Given this list of marker genes Malt1, Nlrp2, Apc, Casp12, Furin, Fap, Riok3, Serpinb9e, Serpina1c, Ryr1, Magea8, Plg, Bcl2l10, Serpina1d, Selenos, Pzp, Psap, Ins2, Casp8ap2, Timp1, Vwf, Bdkrb2, Bcl10, Mif, Ripk2, Serpinb6c, Rnf139, Stfa3, Serpinb6b, Atp9a, F2rl1, Fn1, F3, Tnfrsf1a, Csta1 (cystatin A1), Atp5f1a, Serpinf2 (NCBI Gene Id 18816), Adamts4, Fadd, Nherf4, Serpina1a, Svs3b, Serpinb6d, Brca2, Ddt, Cstb, Dvl3, Cstdc6, Adamtsl4, Serpinb9h, Tnfrsf10b, Trp53, Itgav, Ttn, Cstdc3, Serpinb3c, Pink1, Bank1, Serpinb9f, Serpine1, A2m, Itgb3, Cst3, Vcp, Mbp, Lonp2, Serpina1b, Csta2, Alppl2, Marchf6, Bfar (bifunctional apoptosis regulator), Thbs1, Anxa2 (annexin A2), Rffl, Alpi, Prnp, Fcer2a, Mug2, Cltc, Xiap, Prkn, Bag6, Hspa1a, Serpinb6e, Col1a2, Tysnd1, Fas, Insl3, Serpina5, Lcor, Aldoa, Polg, Sri (sorcin), Col1a1, Stfa1, Mbl2, Rock2, Magea3, Bin1, Il1r1, Derl1, Sart3, Lcn2, Serpinb3a, Col3a1, Adrm1, Spata2, Kit, Panx1, Elane, Sh3pxd2a, Ldlr, Mbl1, Serpinb13, Ntrk2, Chl1, Cflar, Sumo1, Park7, Stfa2, Serpinb9d, Ccbe1, Svs3a, Cstdc4, Amfr, Ecm1, Tnf, Cd177, Akp3, Serpinb3d, Nlrc4, Ctsg, Syvn1, Pten, Ins1, Magea9, Nos1ap, Serpinb9c, Serpinb6a, Serpinc1, Twnk, Serpinb9b, Hspg2, Flot1, Cstdc5, Stfa2l1, Itga3, Sell, Timp2, Kng1, Hdac3, Cdk5r1, Mug1, Cast, Csta3 (cystatin A family member 3), Serpinb9, Rad23a, Itgb1, Adrm1b, F2rl3, Stim1, Serpinb3b, Gm7298, Fam20c, Kng2, Flot2, Tnfaip3, Serpina1e, Trip4, Magea5, Slc2a13, Lrp1, Slc6a3 (solute carrier family 6 (neurotransmitter transporter, dopamine), member 3), Gsk3b, Dpp4, Nol3, Os9, Ndufs7, Xbp1, Bcl2, Semg1, Comp, Pycard (NCBI Gene Id 66824), Cradd, Hspa1b, Tnfrsf8, Chmp3, Serpinb9g, Nfrkb, Casp3, here is a description of the gene set: studied in species Mus musculus Binding to a protease or a peptidase. Mouse Gene Set: GOMF_PROTEASE_BINDING